Given this list of marker genes SH2D1B, NLRP3 (NLR family pyrin domain containing 3), RAET1G, IL4I1, CD1C, CD96, CCR2, MALT1, IL1B, IL18, NCR1, HMCES, CD80, SLC15A4, CLNK, IL18RAP, STAT5B, MR1, LAG3, HMGB1, SHLD2, CR2, TNFRSF1B, ATAD5, BTK, HPX, IL18R1 (interleukin 18 receptor 1), RIPK3, HLA-H, TAP2, CR1L, RASGRP4, INPP5D, SH2D1A, MAD2L2, HLA-E, TNFSF4, ARID5A, IL20RB, ARG1, ULBP1, HLA-DRB3, TRAF6, NECTIN2, HLA-DRA, TP53BP1, IFNB1, STX7, IL12B, SMAD7, LILRB4, TBX21, SERPINB9, KLRB1, P2RX7, EXOSC6, KLRC3, C4BPB, SPN, CLEC12B, AZGP1, CADM1, ARRB2, SLAMF1, SUSD4, SUPT6H, CEACAM1, KLRD1, KLRK1, IL12A, IL1R1, CD55, HLA-B, VAV1, CYRIB, KMT5C, FCER1G, LTA, PDCD1, HLA-G, RAET1E, IFNA2, EXOSC3, FZD5, AHR, RAET1L, CD40, CR1, HLA-C, TRPM4, PRKAA1, TRAF2, CD81, NECTIN4, AP1G1, RIF1, HAVCR2, HLA-DRB1, PIK3R6 (NCBI Gene Id 146850), FUT7, HFE, PARP3 (NCBI Gene Id 25908), CD1E (CD1e molecule), CD7, MAPK3, C4BPA, HLA-F, NDFIP1, LILRB1, CRK, C3, IL2, APLF, C17orf99, PAXIP1, XCL1, CD28, FOXP3, CLEC4G, TGFB1, FCER2, KLRC4, KLRC2, NCR3, FCGR1A, CD274, IL23A, TIGIT, SLAMF6, STAT5A, CD46, CD226, USP5, PVR, STAT6, FBXO38, CLC, UFL1, MAP3K7, KLRC4-KLRK1, SASH3, CALHM6 (calcium homeostasis modulator family member 6), ZBTB1, KIR2DL4, CD1A (NCBI Gene Id 909), MSH2, DUSP22 (NCBI Gene Id 56940), LEP, TNFSF13, MLH1, KLRC1, CD1B, GATA3, NSD2, PPP3CB, CD160, IL10, IL27RA, GRB2, B2M, PRKCZ, CD1D, TREM2, ULBP3, IL6, CRTAM, PMS2, TNF, LAMP1, ULBP2, SHLD1, IL23R, TFRC, IL4, KMT5B, MICA, FOXJ1, FADD, LGALS9, YWHAG (NCBI Gene Id 96443), HSPD1, KLHL22, ZP3, PTPN6, IL12RB1, RASGRP1, SLC22A13, SERPINB4, FCGR2B, CLCF1, NCKAP1L, IL21, PTPRC, SECTM1, RSAD2, HLA-A, WAS, AGER, SHLD3, IL7R, DENND1B, BCL6, here is a description of the gene set: Human Gene Set: GOBP_REGULATION_OF_LYMPHOCYTE_MEDIATED_IMMUNITY Any process that modulates the frequency, rate, or extent of lymphocyte mediated immunity. species: Homo sapiens